The following is a description of a gene set: Mouse Gene Set: GOBP_NEGATIVE_REGULATION_OF_ORGANELLE_ORGANIZATION species: Mus musculus Any process that decreases the frequency, rate or extent of a process involved in the formation, arrangement of constituent parts, or disassembly of an organelle., and this is the list of marker genes: Wdr44 (WD repeat domain 44), Pif1, Pick1, Huwe1, Rad50, Cenatac, Ccdc88c, Pfn2, Bmp7, Kifc1, Mphosph9, Opa1, Vill, Kat2b, Hdgfl3, Tmod1, Bak1, Fbxo5, Mad1l1, Recql4, Arrb2, Tacstd2, Anapc15, Apc, Ier3, Ska3, Dlc1, Cdca8, Xrcc1, Ehmt2 (NCBI Gene Id 52041), Tpr, Kank3, Cdk5rap2, Igf1, Kntc1, Capzb, Hnrnpc (heterogeneous nuclear ribonucleoprotein C), Fgf13, Swap70, Prkcd, Zfp207, Sec22b, Lmod2, Mfn1, Bmp4, Slit2, Prkn, Capg, Hip1r (huntingtin interacting protein 1 related), Myadm, Mul1, Tmod4, Mdm1, Tesk1, Hdac6, Specc1l, Rhpn1, Ssh1, Avil, Ghitm, S1pr1, Mid1, Prelid1, Fgfr2, Psmg2, Scfd1, Tmsb15l, Pparg, Arap1, Bmerb1, Clstn3, Tlr2, Mkks, Lrrk2, Nuf2, Nupr1, Mad2l1bp, Pot1b, Tfrc, Npm1, Smad4, Trim9, Tpm1, Pml, Cracd, Tnks, Slc25a5, Mad2l1, Nat10, Inpp5k, Pik3r1, Rdx, Arhgap6, Ppp1r9a (NCBI Gene Id 72734), Sptb, Triap1, Ercc1, H3f3b, Tmem14a, Gclc, Syt4, Mtm1, Ska1, Trim32, Lmod3, F11r, Rps6ka2, Trim54, Atxn7, Camsap1, Arfgef1, Map2, Ttk, Nanos2, Akt1, Parl, Eml4, Cib1, Fxn, Diaph3, Bnip3, Naa10, Camsap3, Bub1b, Dyrk1a (NCBI Gene Id 76465), Ctc1 (CTS telomere maintenance complex component 1), Ctnna2, Pcid2, Pfn1, Capza1, Ssh2, Map1b, Luzp1, Styxl1, Sgk1, Ccp110, Higd1a, Becn1, Rp1, Slc25a4, Phldb2, Tbcd, Dnm2, Nbdy, Gen1, Pink1, Kank2, Tex14, Capza1b, Baz1b, Tubb4a, Tchp, Arhgef7, Ppargc1a, Stmn2, Ppif, Haspin, Lif (leukemia inhibitory factor), Wasf2, Add3, Psmd10, Patl2 (protein associated with topoisomerase II homolog 2 (yeast)), Bbs4, Mtbp (NCBI Gene Id 105837), Lima1, Birc5, Dmtn, Mak, Mtor, Anapc15-ps, Prap1, Acaa2, Odf2l (outer dense fiber of sperm tails 2-like), Coro1a, Capn1, Acd, Shank1, Usp44, Plk1, Mapre1, Spta1, Flcn, Sptbn1, Tbc1d7, Lcmt1, Eps8, Clip3, Tmem67, Map1a, Pecam1, Fez2, Arhgap33os, Tjp1, Stmn1, Gdi2, Smarca5, Mpv17l, Mfn2, Gpx1, Zfy2, Trim37, Vat1, Osm, Frmd7, Nme6, Esr1, Dbnl, Twf1, Marchf7, Fzd9, Dusp1, Klhl22, Spef1, Iqschfp, Rhpn2, Fhod3, Tnks2, Terf1, Apc2, Exosc10, Usp10, Evi5l, Tmsb15b2, Gmfg, Pak2, Bcl2l2, Hnrnpu, Snca, Gas2l2, Mcrs1, Myh9, Ankrd27, Spc25, Dnm1l, Yap1, Tpx2, Rbm14, Ckap2, Wdr47, Plekhh2, Taok1, Ppfia1, Kif24, Clasp1, Arhgap28, Tbc1d4, Cep97, Twf2, Eml2, Smcr8 (NCBI Gene Id 69685), Spdl1 (spindle apparatus coiled-coil protein 1), Mid1ip1, Nol3, Coro2b, Sptan1, Shroom2, H3f3a, Evl, Gnl3l, Ten1, Flii, Arpin, Carmil2, Togaram2, Limk2, Tbc1d30, Coro1b, Met, Smg6, Khdc3, Zwilch, Gsn, Xrcc4, Bok, Bbof1, Nav3, Prpf4b, Espn, Parp1, Rad1, Hormad1, Camsap2, Katnb1, Cdh5, Atm, Gmfb, Spc24, Terf2ip, Clasp2, Scin, Terf2, Tmod2, Ccnf, Bub1, Lmod1, Vil1, Carmil1, Prrt2, Phf23, Adck1, Map6d1, Kank4, Knl1, Tinf2, Kank1, Fnip1, Bcl2l1, Fbxo43, Dbn1, Slx4, Bub3, Tmem39a, Setmar, Cdc20, Wapl, Ik, Hgf, Dnai3, Tent4b, Kat2a, Lpar1, Tom1l2, Zwint, Add2, Myoc, Mapt, Zw10, Avp, Nubp1, Slc25a31, Tmeff2, Arhgef2, Ccnb1-ps, Was (Wiskott-Aldrich syndrome), Ttbk2, Pik3ca, Carlr, Rad21, Add1, Dync1li1, Aurkb, Cgnl1, Rtel1, Oma1, Mtpn, Trp53, Pot1a, Atrx, Pinx1, Arhgef18, Cenpe, Chek1 (checkpoint kinase 1), Lmna, Slc35f6, Ccnb1, Xrcc3, Ndc80, Shank3, Inpp5j, Tmsb4x, Arpc2, Fgfr3, Tmod3, Fkbp4, Capza2, Fez1, Cdk10, Capza3, 4930550C14Rik, Dmrt1, Trip13, Cfl1, Stn1 (STN1, CST complex subunit), Src, Nbn, Ercc4, Cyrib, Ssh3, Dcp2, Cav3, Gas2l1, Cep192, Tom1l1, Svil, Map3k1 (mitogen-activated protein kinase kinase kinase 1), Incenp